The following is a description of a gene set: Binding to a mitogen-activated protein kinase kinase kinase, a protein that can phosphorylate a MAP kinase kinase. Human Gene Set: GOMF_MITOGEN_ACTIVATED_PROTEIN_KINASE_KINASE_KINASE_BINDING species: Homo sapiens, and this is the list of marker genes: MAP3K11, SASH1, PPARA, TCF3, DUSP19, PPEF2, PPP5C, MARVELD3, TRAF2, DAZAP2, MAPK8IP1, TRIM72, MAP2K1, STK38, MAP4K2, ROR2, DAB2IP